The following is a description of a gene set: studied in species Mus musculus Human Gene Set: RASHI_RESPONSE_TO_IONIZING_RADIATION_2 The ATM protein kinase, functionally missing in patients with the human genetic disorder ataxia-telangiectasia, is a master regulator of the cellular network induced by DNA double-strand breaks. The ATM gene is also frequently mutated in sporadic cancers of lymphoid origin. Here, we applied a functional genomics approach that combined gene expression profiling and computational promoter analysis to obtain global dissection of the transcriptional response to ionizing radiation in murine lymphoid tissue. Cluster analysis revealed a prominent pattern characterizing dozens of genes whose response to irradiation was Atm-dependent. Computational analysis identified significant enrichment of the binding site signatures of NF-kappaB and p53 among promoters of these genes, pointing to the major role of these two transcription factors in mediating the Atm-dependent transcriptional response in the irradiated lymphoid tissue. Examination of the response showed that pro- and antiapoptotic signals were simultaneously induced, with the proapoptotic pathway mediated by p53 targets, and the prosurvival pathway by NF-kappaB targets. These findings further elucidate the molecular network induced by IR, point to novel putative NF-kappaB targets, and suggest a mechanistic model for cellular balancing between pro- and antiapoptotic signals induced by IR in lymphoid tissues, which has implications for cancer management. The emerging model suggests that restoring the p53-mediated apoptotic arm while blocking the NF-kappaB-mediated prosurvival arm could effectively increase the radiosensitivity of lymphoid tumors. Cluster 2: late ATM dependent genes induced by ionizing radiation treatment. from publication Rashi-Elkeles S, Elkon R, Weizman N, Linhart C, Amariglio N, Sternberg G, Rechavi G, Barzilai A, Shamir R, Shiloh Y (PMID 16314843), and this is the list of marker genes: HIVEP1, TACSTD2, CAPN3, PCP4L1 (Purkinje cell protein 4 like 1), PDE4B, RNF19B, CEBPD, ALOX12, SOX4, DUSP16, PLK2 (polo like kinase 2), HP, CDKN1A, NFKBIB, KLF5, LAMC2, THBS1, RNPS1, MGLL, STXBP1, DUSP6, RELL1, NFE2L1, NFKBIA, CXCL2, RHOU, RAB5B, ATF3, DSC2, PLSCR1, RLIM, TCF25 (transcription factor 25), TAGLN2, MAPKAPK2, SNHG11, RAB10 (NCBI Gene Id 51140), LGALS3, INPP5A, NFE2L2, BTG2, PVR, BTG1, RBMX, GPCPD1, CXADR, IFNGR2, STAT3, OCLN, TNIP1, TIMP3, JUNB, PTPRA, SQSTM1, N4BP1, ACTA2, VPS37B, GALC, SRPRA, C19orf48P, TUBB2A, CLDN7, SPRR1A, CSF1, TNFAIP3, SINHCAF, IRF6, HIPK2, OSER1, DENND5A (DENN domain containing 5A), CSRP2, S100A13, GJB5, BIRC3, TRIB3, ANXA1, KLF10, CLDN4, RNF19A, PRSS23, GNAI3, SPOP (NCBI Gene Id 8405), RBPJ, ERBB3, MAN2B1, PKP3, BCL10, APAF1 (apoptotic peptidase activating factor 1), PHLDA3, KRTAP6-1, EDN1, HIVEP2, CX3CL1, CFTR, TGFB2, NGF, GAB1, SLC11A2, RELB, KRT19, SOCS2, PCGF2, ZWINT (NCBI Gene Id 11130), WWTR1, BAX (BCL2 associated X, apoptosis regulator), NFKB2, RELA, KLF4, TRDC, SLC7A7 (solute carrier family 7 member 7), LCN2, B4GALNT1, MDM2, NFKBIZ, DENND2B, TRAF3, IRF1, TGIF1, CD14, KLF6, MAP3K8, GNA13, OR4E2, ICAM1, SDHAF1, CISH